Given this list of marker genes Mir145b, Gm21046, Mbd2, Ldlrad4, A730085E03Rik, Mc2r, Poli, Stard6, Dynap, Gm31819, Gm31908, Snord58b, Lipg, Myo5b, Mro, Dynapl1, D730045A05Rik, Gm29677, 4930546C10Rik, Mir6357, Gm18786, Gm23301, Acaa2, Gm30641, Elac1, Gm6995, Rab27b, Gm32548, BC031181, Rnmt, 1700120E14Rik, Mc5r, 4930448D08Rik, Dcc, Scarna17, 9030625G05Rik (NCBI Gene Id 71545), Mex3c, Ska1, Rpl17 (ribosomal protein L17), Gm14328, Gm31294, Gm23119, Gm5690, Fam210a, Gm41764, Cxxc1, Gm18963, Gm8934, 4930503L19Rik, Dym, Gm26202, Gm18149, Tcf4, Gm4402, Me2, Mbd1, Gm8986, 1700061H18Rik, Mir7219, Cfap53, Rpl37a-ps2, Smad4, Gm17943, Mir6356, Mapk4, Ccdc68, Gm4842, here is a description of the gene set: species: Mus musculus Mouse Gene Set: chr18E2